The following is a description of a gene set: Mouse Gene Set: REACTOME_OTHER_SEMAPHORIN_INTERACTIONS Other semaphorin interactions species: Mus musculus, and this is the list of marker genes: Sema3e, Sema4a, Sema7a, Cd72, Plxnc1, Plxna1, Trem2, Plxnb3, Sema6d, Sema4d, Sema5a (NCBI Gene Id 320921), Tyrobp, Ptprc, Plxnd1